The following is a description of a gene set: Annual influenza vaccinations are currently recommended for all individuals 6 months and older. Antibodies induced by vaccination are an important mechanism of protection against infection. Despite the overall public health success of influenza vaccination, many individuals fail to induce a substantial antibody response. Systems-level immune profiling studies have discerned associations between transcriptional and cell subset signatures with the success of antibody responses. However, existing signatures have relied on small cohorts and have not been validated in large independent studies. We leveraged multiple influenza vaccination cohorts spanning distinct geographical locations and seasons from the Human Immunology Project Consortium (HIPC) and the Center for Human Immunology (CHI) to identify baseline (i.e., before vaccination) predictive transcriptional signatures of influenza vaccination responses. Our multicohort analysis of HIPC data identified nine genes (<i>RAB24</i>, <i>GRB2</i>, <i>DPP3</i>, <i>ACTB</i>, <i>MVP</i>, <i>DPP7</i>, <i>ARPC4</i>, <i>PLEKHB2</i>, and <i>ARRB1</i>) and three gene modules that were significantly associated with the magnitude of the antibody response, and these associations were validated in the independent CHI cohort. These signatures were specific to young individuals, suggesting that distinct mechanisms underlie the lower vaccine response in older individuals. We found an inverse correlation between the effect size of signatures in young and older individuals. Although the presence of an inflammatory gene signature, for example, was associated with better antibody responses in young individuals, it was associated with worse responses in older individuals. These results point to the prospect of predicting antibody responses before vaccination and provide insights into the biological mechanisms underlying successful vaccination responses. Genes down-regulated in peripheral blood mononuclear cell high responders vs low responders in younger adults (21-35) (high responders) after exposure to trivalent influenza vaccine (TIV), time point 0D. Comment: data from six different cohorts, trivalent vaccine year not specified from publication HIPC-CHI Signatures Project Team, HIPC-I Consortium (PMID 28842433) studied in species Homo sapiens Human Gene Set: HIPC_SIGNATURES_PROJECT_PBMC_TRIVALENT_INFLUENZA_VACCINE_HIGH_RESPONDERS_VS_LOW_RESPONDERS_YOUNGER_ADULTS_21_35_HIGH_RESPONDERS_0D_DOWN, and this is the list of marker genes: CASP6, PURA, PTPN22, SP4, NUDCD2, PPIB